The following is a description of a gene set: part of: Signaling by TGF-beta Receptor Complex Reactome Pathway: TGF-beta receptor signaling activates SMADs species: Mus musculus electronically inferred by orthology from the curated human pathway This event has been computationally inferred from an event that has been demonstrated in another species.<p>The inference is based on the homology mapping from PANTHER. Briefly, reactions for which all involved PhysicalEntities (in input, output and catalyst) have a mapped orthologue/paralogue (for complexes at least 75% of components must have a mapping) are inferred to the other species., and this is the list of marker genes: Tgfb1, Cbl, Itgb5, Fkbp1a, Ltbp3, Rps27a, Bambi, Smad3, Smurf2, Ubb, Nedd8, Smad7, Mtmr4 (NCBI Gene Id 170749), Itgb8, Ltbp2